Given this list of marker genes Afg3l2, Ubr5, Zer1, Rnf126, Atxn3, Hdac6, Irgq, Lonp1, Zyg11b, Proca1 (protein interacting with cyclin A1), Ube2w, Stub1, Ubr4, Cul3, Klhl15, Lonrf2 (LON peptidase N-terminal domain and ring finger 2), Tmem126a (transmembrane protein 126A), Afg1l, Lonp2, Akirin2, Vcp, Yme1l1, Clpp, Ankzf1, Fbxl17, Oxa1l, Saysd1, Oma1, here is a description of the gene set: studied in species Mus musculus The chemical reactions and pathways resulting in the breakdown of misfolded or attenuated proteins. Mouse Gene Set: GOBP_PROTEIN_QUALITY_CONTROL_FOR_MISFOLDED_OR_INCOMPLETELY_SYNTHESIZED_PROTEINS